Given this list of marker genes Diaph2, Foxg1, Diaph1, App, Robo3, Robo2, Robo1, here is a description of the gene set: Mouse Gene Set: GOBP_AXON_MIDLINE_CHOICE_POINT_RECOGNITION species: Mus musculus The recognition of molecules at the central nervous system midline choice point by an axon growth cone; this choice point determines whether the growth cone will cross the midline.